Given this list of marker genes Rai2, Csde1, Kpna4, Gan, Pi15, Zc3h12c, Sec63, Cux1 (NCBI Gene Id 384239), Hoxd10, Adamts3, Bcor, Fzd4, Arpp21, Sema3c, Csnk1a1, Fbn2, Zmym4, Nono, Wdr48, Ldha, Cbll1, Samd12, Lair1 (NCBI Gene Id 71224), Clasp2, Blzf1, Fgfbp1, Mycn, Larp4b, Osbpl8, Bcl7a, Hycc2, Adcy2, Cnot9 (CCR4-NOT transcription complex, subunit 9), Acvr2b, Dpp10, Jade1, Ccdc50, Ube2h, Adam23, Kdm7a, Stau2, Rbms1, Zbtb43, Kcnj2, Ndp (NCBI Gene Id 236713), Zfhx4, Kctd9 (potassium channel tetramerisation domain containing 9), Fbxw2, Dapk1, Psmd11, Sbno1, Snx13, here is a description of the gene set: Mouse Gene Set: MIR_500_3P_MIR_501_3P Genes predicted to be targets of miRBase v22 microRNA mmu_miR_500_3p, mmu_miR_501_3p in miRDB v6.0 with MirTarget v4 prediction scores > 80 (high confidence targets). from publication Chen Y, Wang X (PMID 31504780) studied in species Mus musculus